Given this list of marker genes Ttc8, Aimp1, Vdac2, 3000002C10Rik (NCBI Gene Id 384982), Psmd12, Slx4ip, Tbck, Eftud2, mt-Tp, Rufy2, Xpnpep3, Fars2, Skp1, Trap1, Dnal4, Rpn1, Cs, Iscu, Ddx39b, Nme6, Ap3m1, Pno1, Rps23, Ndufa10, Zfp383, Dzank1, Nsun2, Spcs1, Adk, Rbks, Sec61b, Dgkz, Ube2i, Upf2, Rdh10, Pcbp1, Alg2, Ak6, Phf14, Amz2, Pdcd6ip, Bud31, Gm25744, Wdr47, Gm15420, Rps12, Efnb1, Supv3l1, Nhlrc3, Rpl35a, Birc2, Emc1, Mir6236, Zranb2, Gga3, Tomm20, Ccdc43, Dync1li2, Chd8, Bckdha, Vcf1 (VCP nuclear cofactor family member 1), Babam2, Stam2, Smc2, Nup85, Mrps5, Ccdc103, Polr2e (polymerase (RNA) II (DNA directed) polypeptide E), Smc2os, Anapc7, Zfp729b, Rbbp5, Fam162a, Iqcg, Gm26397, Hadha, Ice1, Atp5mg, 1600020E01Rik, Sec11c, Alkbh5, Tm9sf1, Cdc73, Lyrm4, Stamos, Gm26802, Hadhb, Hilpda, Rpl7, 6030442K20Rik, Suds3, Nup205, Dctn1, Polr3f, Rabggtb, Stam, Ankle2, Sf3b3, Tubd1, Eif4h, Ubr4, 2410002F23Rik (NCBI Gene Id 66976), Fam222b, Mrps7, Tsn, Taf9, Selenof, Rexo1, Izumo1 (izumo sperm-egg fusion 1), Rad17, Ptges2, Hspa9, Suclg1, Chchd4, Pin4, Mkks, Rps6kb1, Sart3, Caprin1, Ipo13, Zfp738, Gm23130, Arhgap11a, Dph6, Usp1, Ddx31, Rabl2, Psmg2, Urod, Blcap, Gm8357, Pak1ip1, Gtf3c4, Pes1, Hectd3, Pcbd2, Cog4, 1110038B12Rik, Rps10, Irgq, Hs2st1, Gosr2, Cnpy2, Rpl21, Zfp661, A730081D07Rik, Mapkapk5, C920009B18Rik, Nat10, Vti1b, Cep76, Ncln, Dnaaf10, Mix23, Tmed1, Pi4kb, Vars1, Ufm1, Clhc1, Ndc1, Slc35b1, Psmd1, Farsb, Anapc1, Snord45c, Actr10, Zfp335os, Bag6, Mrpl11, Mrpl9, Pdap1, Ptges3, Proser1, Tmem43, Eif2s3x, Lrr1, Ndufa4, Rps24, Cactin, St13, Rps27a, Cox7a2l, Eif4enif1, Mtnap1, Gorab, Mrto4, Cct4, Zfp729a, Srd5a1, Exosc5, 4930592C13Rik, here is a description of the gene set: from publication Yevshin I, Sharipov R, Kolmykov S, Kondrakhin Y, Kolpakov F (PMID 30445619) Mouse Gene Set: ZFP335_TARGET_GENES studied in species Mus musculus